The following is a description of a gene set: Broad jaw Human Gene Set: HP_BROAD_JAW species: Homo sapiens Bigonial distance (lower facial width) more than 2 SD above the mean (objective); or an apparently increased width of the lower jaw (mandible) when viewed from the front (subjective)., and this is the list of marker genes: ANO5, SNIP1 (Smad nuclear interacting protein 1), AIP, LRP5, GPR101, SH3BP2